Given this list of marker genes ZNF732, ZNF600, MEF2C, EID2B, ZNF708, PLEKHA1, ZNF728 (zinc finger protein 728), GABRG2, ZNF225, ZNF816, DOK2, CLCF1, ZNF107, GPR158, PECR, ZNF737, CASP8, TRPV2, ZNF468 (zinc finger protein 468), ZNF730, UROS, ZNF493, RGL2, GRM3, NOP10, VSNL1, ABHD13, CLN8, AMMECR1L (AMMECR1 like), MAX, FXR1, AURKA, ZNF117, YPEL2, VGLL2, SLC25A41, CD164, MICAL2, TAPT1, HOXC11, PDCD10 (programmed cell death 10), ZNF710, SOX6, ZNF676, ZNF28, ZNF138, ZNF99, ALCAM, FBXO42, FBXW7, OXR1, ZNF611, KDM5A, ARHGAP27, SETD3, CCDC186, XK, ARHGEF5, TENT4B, MAP3K12, PPP1R3B, BPTF, VSTM2A, LAMC1, FIGN, ZNF208, RAB3B, EPO, VSIG10L, here is a description of the gene set: Genes predicted to be targets of miRBase v22 microRNA hsa-miR-4715-3p in miRDB v6.0 with MirTarget v4 prediction scores > 80 (high confidence targets). from publication Chen Y, Wang X (PMID 31504780) studied in species Homo sapiens Human Gene Set: MIR4715_3P